The following is a description of a gene set: Disorders of galactose metabolism Human Gene Set: WP_DISORDERS_OF_GALACTOSE_METABOLISM studied in species Homo sapiens, and this is the list of marker genes: GYG2, GALT, PYGL, GYS1, PGM1, SLC5A1, SLC2A2, GYS2, GYG1, AKR1B1, GALK1, GBE1, GALE